Given this list of marker genes GLYR1, YIPF4, RAB8B, CIC, NIPBL, MAP3K20, BTG2, ZFHX4, COL5A1, ZFYVE21, RPL15, HYCC2, MAP2K4, MED19, FBN1, TET2, EOMES, ZNF827, MAST4, VPS4B, ARHGAP24, ARPC2, MMD, RPS6KA4, ZNF595, FAM81A, FNIP1, REXO1 (NCBI Gene Id 57455), PITPNM2, DAAM1, PPCS, STYX, TBC1D12, GTF2A1, GRM7, RANBP9, PPP1R37, HIPK1, ZNF721, PCDH11Y, CLCN5, CDK16, BCL11B, RAB14, SLC4A8, PAX3, MCOLN2, PCGF3, GID4, TPCN1, HIPK3, NEFH, FHIP2A, MCL1, BSDC1, ADAM19, GPR180, PCDH11X, SNAPC1, HERPUD2, PUS7, TAGAP, MYO5A, GOLGA7, RAD21, ZNF521, ANKRD28, FOSL2, IRS2, KLF8, PHF3, CBLN4, ZFC3H1, PIK3AP1, CCNC, TBL1XR1, CDCA7L, RNF4, SLC9A1, ZC2HC1A, FAM135A, GLRA1, SLC39A8, COG3, NSMF, SPTBN4, EDEM3, DOCK9, EDEM1, SLC24A3, ANKRD44, TRIM36, ADAMTSL1, FXR1, SFXN1, ADGRF2P, ABHD13, COX20, CNIH1, FAM24A, EPG5, TMEM229A, SEMA3A, MAP1B, BCL2L11, CHRM5, SRPRA, GPBP1L1, CALN1, DNAJB9, RGS17, NOX4, PDZD8, RGL1, KLHL11, ZFAND1, FHIP1B, C6orf62, ROBO2, DDX3Y, PAX9, SLC38A2, B3GALT2, DUSP10 (NCBI Gene Id 11221), STX17, SLC25A32, ITGA6, SERTAD2, SH3D19, UBE2Z, PLEKHA1, SGK3, IQGAP2, MPP1, XYLT2, TMEM267, ATP7A, PIK3CB, CELF2, RNF180, NEFL, NFYB, PTGER4, TAFA1, IDH1, STRN3, ITPRID2, CPEB4 (NCBI Gene Id 80315), COL19A1, SELENOT, PDE10A, VWA5B2, MAGEC2, PALLD, CLDN11, NCAPH2, NSMAF, PTEN, DUSP5, IBTK, USP45, RBPMS2, MORC3, INSIG1, MYCBP2, HNF1B, PTPRJ, COL27A1, SH3PXD2A, MACIR, WASL, TTC9 (NCBI Gene Id 23508), PTAR1, ESRP1, HS3ST5, FNIP2 (folliculin interacting protein 2), TEF, SLC25A36, TRIO, USP36, SLC17A6, SNX13, ARHGEF17, SCUBE3, MAPK8, TENT4A, GNPDA2 (NCBI Gene Id 132789), ASPN, MOAP1, ATRX, MARCHF4, DYRK2, HIVEP1, LONRF3, ITGA5, SNAP91 (synaptosome associated protein 91), SOSTDC1, FBXW7, FOXN2, LHFPL2, NEDD4L, SLC9A7, ATP6V1B2, PPP1R12A, PCOLCE2, MIA3, JMY, ANO8, TMEM255A, SOX11, ITGAV, SERINC5, SPRYD4, CDKL5, SLC7A11, EVI5, RHPN2, SSBP2, SETD5, PLEKHG3, KLHDC10, REST, XPNPEP3, MBOAT2, ITPR1, GRHL1, GPR158, KLHL14, ZNF230, CPEB3, PTPRK, CFAP263, NRG1, ERGIC2, NEFM, MYH9, LIN54, PGBD2, DMXL1, PCMTD1, C5orf24, LIMCH1, PCYT1B, GOLGA4, KLHL15, TEX2, LRRC1, DDX3X, ARF1, TOB1, NPNT, PER2, CXCL5, AIDA, CNEP1R1, NF2, LRCH1, ITGA8, ACOX1, ATXN1, DNAJB12, BCL11A, HAND2, RORA, PRKAR2B, PIP5K1C, WWP2 (NCBI Gene Id 116013), RIMS2, UGP2, EFR3A, ZEB2 (zinc finger E-box binding homeobox 2), ANKIB1, AGO3, ST6GAL2 (NCBI Gene Id 84620), MIER1, CPNE8, PIK3CA, GFPT2, ACTC1, SLC10A7, CBFA2T3, UBE2W, NFYC, NR4A3, AFF3, RNF11, FNBP4, ANP32E, SYNJ1, FHL2, KLHL29 (kelch like family member 29), CACNA1I, PDZD2, RSBN1, LATS2, NOTCH1, SESN3, MAN2A1, SCN8A, ELOVL4, ZNF287, GPR137C, MFF, EPC2, DSTYK, GLCE (NCBI Gene Id 90998), PIKFYVE, GATA2, RBM47, DOCK5, GRIA1, SGPP1, MMP10, ZNF804A, PTPRO, OSBPL5, PLEKHB2, BSN, ATXN3, TNPO1, PPP1R12C, GPC6, BCAT2, NSF, FMR1, UCHL5, FAM20C, TOB2, GNAQ, ADAMTSL3, ALKAL2, UBXN4, OTUD4, ZNF24, CUX1, C8orf44-SGK3, RBM27 (NCBI Gene Id 54439), ELK4 (NCBI Gene Id 2005), APPL1, KLF2, RAB3C, SLC32A1, PAXBP1, TULP4, TECPR2, HCN2, MEF2D, SNN, RNF38, RAB23, ATG14, PNISR, PSMD14, G3BP2, ZNF532, RGS3 (regulator of G protein signaling 3), CCDC186, KAT2B, PHTF2, FKBP1A, TCF21, LYST, GOLGA3, P3H3, TEAD1, GRAMD2B, OTUD3, ARRDC3, TWF1, MTMR9, SCAF11, BAHCC1, PRRC2B, ARMC1, CASD1, ELOA, BAZ2B, BLTP1, ADRB1, NKX2-3, PITPNA, TACC2, KMT5B, NCKAP5, SBNO1, C11orf24, TBC1D8, SYN2, SERTAD3, SOCS6, ZDHHC5, ADCY3, SOX4, CADM2, PKDCC, DTX2, PAPSS2, MTF1, SLC12A5, KLF4, CHCHD10, FMN2, DENND4B, GOLGA8A, GOLGA1, PRSS12, JOSD1, NIPAL1, SLC25A16, PEAK1, TSC1, ARRDC4, TWIST1, NUFIP2, PAPOLA, GIT2, FZD10, ARID1B, UBASH3B, MYO1B, PTGES2, RNF44, FCHO2, FRY, CD2AP, KBTBD8, COL1A2, DNAAF9, PCDH7, SLX4, CTTNBP2, MYLIP, TGIF1, BMPR2, NPC1, IL36B, C21orf91 (chromosome 21 open reading frame 91), RIC1, MINAR1, RNF141, ASPH, DUSP6, DUS2, LMBR1L, TMF1, PIK3R3, MSR1, AADACL3, LUZP1, C19orf12, ADAM10, APBB2, DCAF6, ZNF385D, PTPRD, FBXO28, MFHAS1, DPP10, CSMD3, SEC31B, PHLPP2, DENND1B, RFX1, MAP7D3, CD69, CPEB2, GATA6, CCNJL, DSC2, TPPP, NKX2-4, PLXDC2, PIAS4, USP28, here is a description of the gene set: species: Homo sapiens Human Gene Set: MIR92B_3P Genes predicted to be targets of miRBase v22 microRNA hsa-miR-92b-3p in miRDB v6.0 with MirTarget v4 prediction scores > 80 (high confidence targets). from publication Chen Y, Wang X (PMID 31504780)